Given this list of marker genes HPD, FAH, HGD, GSTZ1, TAT, here is a description of the gene set: studied in species Homo sapiens Human Gene Set: KEGG_MEDICUS_REFERENCE_TYROSINE_DEGRADATION Tyrosine degradation. Pathway ID: N00708. Pathway type: Reference. Pathway class: nt06016 Phenylalanine and tyrosine metabolism. Pathway Definition from KEGG: Tyr -- TAT >> HPD >> HGD >> GSTZ1 >> FAH -> Fumarate+Acetoacetate